Given this list of marker genes TRMT1L, PIGC, L2HGDH, PGM2L1, PAN2, SERPINC1, AGR3, RIF1, PTS, UBXN7, RSRP1, DCAF17, STX16, TSPAN13, ZBTB41, SLC5A3, SCD, HSPA1B, USP9X, EIF2S3, PTBP2 (polypyrimidine tract binding protein 2), ELMO1, RPA2, TMEM245, RBM15, EPSTI1 (NCBI Gene Id 94240), NABP1, MCM8, ZMYM5, CBFB, ATAD1, KLHL26, CDC45, DBR1, CDC25A, PWWP2A, PAPOLG, C12orf75, LSM14A, LATS1, ZSCAN21, SERTAD2 (NCBI Gene Id 9792), FAM8A1, PRPS2, PEX1 (peroxisomal biogenesis factor 1), CCT4, ZFYVE27, IPCEF1, YWHAB, TNNI1, TOP1, PUS7, PHC3, AASDH, SERPINB9, ZNF770, GARIN3, TEX10, TAF1D, RPS6KB1, CCNT1, TASOR2, FYN, IREB2, IKZF2, MDM4, SMARCA5, ZC3H11A, SLF1, MOB1B (MOB kinase activator 1B), WDR44, ARID4B, ITGB1, IFIT2, OBI1, OTUD4, HMGCR, PCGF5, TNFSF8, TRMT13, OVGP1, XIAP, PTCD3, STK26, VRK2, ARHGEF3, SGMS1, DOP1B, FEM1B, PLAGL1, FIRRM, LUC7L3, PHF14, GPR34, TUBGCP5, C5orf22, SRRM2, RBAK, ALKBH1, PNN, POM121 (POM121 transmembrane nucleoporin), ACAD8, PRMT3, CD48, PKIB, IQCB1, COP1, PPP1R15B, MID1, CENPE, BORA, RFX5, PRPF39 (NCBI Gene Id 81951), KANSL2, TP53BP1, HSPH1, WIPF1, IL15RA, MAT2A, SKP2, KDM6A, SPIN4, DNM1L, MORC3, ZCCHC2, RPS3, ZNF106, HSPA1A, AIM2, SBF2, SIK3, DENND1B, TCERG1, SLC19A2, NAA20, ANTXR2, SIMC1, ASH1L, ERCC6L2, NEK9, IFITM3, PHLDA1, WAPL, RHOD, PLCXD2, CNOT6L, TTPAL, SLC7A6, BLMH, SEC11C, FAF1, WDR75, SHQ1 (SHQ1, H/ACA ribonucleoprotein assembly factor), ZDHHC21, MOSMO, KHDC4, PTDSS1, ANKRD6, DUSP5, DSEL, HAUS6, CXorf38, GABPA, ITPR1, EXOC1, NCF1, PSIP1, PTPN11, TAF15, AHCTF1, CEP68, JMJD1C, SLC25A3, PPIC, TFRC (NCBI Gene Id 7037), IL2, SH2D1A, MSH3, TOPBP1, RIMOC1, ZNF592, TMEM62, ST8SIA4, CRIM1, SACM1L, ESYT2, PDIA5, CEP192, CCDC117, PSMC2, SELL, CREB1, PTPRC, SETD6, FOXN3, ABTB3, ABCB7, CD274, NEFH, here is a description of the gene set: studied in species Homo sapiens Human Gene Set: GSE39820_CTRL_VS_TGFBETA1_IL6_IL23A_CD4_TCELL_UP TGF-beta3 produced by developing Th17 cells induces highly pathogenic T cells that are functionally and molecularly distinct from TGF-beta1-induced Th17 cells. The microarray data represent a distinct molecular signature for pathogenic versus non-pathogenic Th17 cells. Genes up-regulated in comparison of untreated CD4 T cells versus those treated with TGFB1, IL6 and IL23A. from publication Lee Y, Awasthi A, Yosef N, Quintana FJ, Xiao S, Peters A, Wu C, Kleinewietfeld M, Kunder S, Hafler DA, Sobel RA, Regev A, Kuchroo VK (PMID 22961052)